The following is a description of a gene set: Genes down-regulated in comparison of CD4 CD8 Int thymocytes versus CD8 thymocytes. studied in species Homo sapiens T cell development relies on the precise developmental control of various cellular functions for appropriate positive and negative selection. Previously, gene expression profiling of peptide-driven negative selection events in the N15 TCR class I MHC-restricted mouse and D011.10 TCR class II MHC-restricted mouse has offered insights into the coordinate engagement of biological processes affecting thymocyte development. However, there has been little comparable detailed in vivo global genome expression analysis reported for positive selection. We used microarrays to identify the genes differentially expressed during CD8 single positive T cell development in N15 TCR transgenic Rag2 deficient mice. from publication Choi YI, Duke-Cohan JS, Ahmed WB, Handley MA, Mann F, Epstein JA, Clayton LK, Reinherz EL (PMID 19027330) Human Gene Set: GSE13493_CD4INTCD8POS_VS_CD8POS_THYMOCYTE_DN, and this is the list of marker genes: MFSD5, ZC3H12D, ATP6V1G2, NTN4, EML3, CACNB4, DFFB, RPS18, RECK, TAF1C, MTX3, IL17RA, CEP350, IFT140, UTS2, GRB14, PLP2, ABHD5, NSMF, HS1BP3, VRK3, BOLA2, CNP, HAO2, TSFM (Ts translation elongation factor, mitochondrial), KLHL18, MKNK2, ARHGEF9, S1PR4, SNX9, ADRA2B, RABL6, FCMR, EEF1B2, DNAJC5B, SLC24A2, IMPG1, SCRT2, SMCHD1, ENC1, CAMSAP2, FCAMR, C2CD2L, TAS1R2, LAPTM5, MYH7, EIF2AK2, IGHM, SLC39A6, TOM1 (target of myb1 membrane trafficking protein), DNASE1, RPL4, FBXO16, NAP1L5, RCL1, ABCC4, CDH23, CEP135, DNAJC22, NTRK3, IGFBP4, ELN, SMR3A, ITGAE, HAAO, GUCY2D, SLC4A4, CISD3, AREG, IDO1, ZNF446, TNS1, SLC26A11, MBOAT7, TTLL7, DPH5, CD72, SPON1, OSBPL7, ABRA, PKMYT1, TMEM214, ARFGAP2, G3BP1, TOP1MT, SERBP1, REXO2, DNAJB13, PTPRT, PCP2, SEMA4F, TRADD (TNFRSF1A associated via death domain), ADCY7, PSEN2, VCPKMT, ROPN1L, DGKA, PLSCR1, D2HGDH, SYMPK, NAPEPLD, PRR13, EIF1 (NCBI Gene Id 1963), GMPPA, ZPR1, TPP1, MAPK15, CABCOCO1, PGAP6, SAMHD1, ABTB3, MAP2K2, CABP4, KCTD4, FGA, ASCL1, IGF2-AS, ZNF503, HID1, CD40, PNPLA7, MDH2, SIPA1, NAT8, CORO2A, EHD1, B3GAT3, TRAF3IP2, KLHL35, NR2F6, PRTN3, ACBD4, ADAMTS4, PARD3B, DCAF4, CRTC2, PRRC2B, EID2 (EP300 interacting inhibitor of differentiation 2), RAB3IP, TGM1, MUSTN1, DHRS7, NCKIPSD, NEURL2, SPATA33, FAM241A, AIRIM, PLEKHA6, GATA4, SPIC, CTHRC1, MGAM, CARS2, IFNLR1, GRAMD4, MYC, GGT1, RNF123, SELL, DPF1, AKAP6, RHOQ, SAFB2, ATP2A1, MED12, SYTL1, LURAP1L, GPR3, SPART, DEFB4A, TMEM202, TMEM239 (transmembrane protein 239), ARHGEF12, SPRYD7, AQR, BATF, OR8A1, LIPC, RUNDC3A, WNT8A, TFAP2E, CDKN1A, FCER1A, PTDSS2, ANKS4B (NCBI Gene Id 257629), RPS4X, HIP1R, ADCK5, TAF10, ARHGEF18, TANC1, ATM, LRP1B, RNF185, TNS2, HLA-DMB, FKBP6, QTRT1